Given this list of marker genes Tspan18, Gigyf1, Taf3, Pwwp2a, Cpa3, Elk1, Usp54, Ddx6, Rabgap1l, Stx5a, Pcdh18, Pip5k1a, Stmn2, Ccnb1, Kif24, Zfp654, Popdc2, Cntnap3, Prickle3, Gak, 9030624G23Rik, Serpinb8, Trem5, Marcksl1, Srebf1, Ubxn8, Nos2 (nitric oxide synthase 2, inducible), Pde6d, Cntrob, Arpc5l, Gjb2, Atp13a4, Tnrc6a, Psmc1, Atat1, Gm5622 (NCBI Gene Id 637481), Ralgapa2, here is a description of the gene set: from publication Chen Y, Wang X (PMID 31504780) species: Mus musculus Genes predicted to be targets of miRBase v22 microRNA mmu_miR_6995_5p in miRDB v6.0 with MirTarget v4 prediction scores > 80 (high confidence targets). Mouse Gene Set: MIR_6995_5P